Given this list of marker genes Il17a, Ppl, Mmp7, Ivl, Il17f, Lgals4, Evpl, Pgc, Klk5, Elane, Nod2, Klk7, here is a description of the gene set: species: Mus musculus Mouse Gene Set: GOBP_ANTIMICROBIAL_PEPTIDE_PRODUCTION The synthesis or release of an antimicrobial peptide during an immune response, resulting in an increase in intracellular or extracellular levels. Such peptides may have protective properties against bacteria, fungi, viruses, or protozoa.